The following is a description of a gene set: studied in species Homo sapiens Any process that activates or increases the frequency, rate or extent of the DNA-dependent DNA replication that occurs in the nucleus of eukaryotic organisms as part of the cell cycle. Human Gene Set: GOBP_POSITIVE_REGULATION_OF_NUCLEAR_CELL_CYCLE_DNA_REPLICATION, and this is the list of marker genes: DBF4B, CDC7, DBF4, INO80, WIZ, FGFR1, ATRX